The following is a description of a gene set: TGFBR3 expression studied in species Homo sapiens Human Gene Set: REACTOME_TGFBR3_EXPRESSION, and this is the list of marker genes: MIR27B, TNRC6B, SMAD3, MIRLET7A1, RARA, TGFBR3, MOV10, MYOD1, SMAD4, TCF3, MIR23B, HELLS, MYF5, MYF6, TCF4, AGO4, TNRC6A, AGO1, KLF16, EP300, MYOG, AGO3, SP1, RXRA, MYCN, TNRC6C, AGO2, TCF12